Given this list of marker genes OGG1, here is a description of the gene set: studied in species Homo sapiens The majority of OGG1 mutants have been tested for their ability to excise 8-oxoguanine (8oxoG) from damaged DNA, while a small number of mutants have been tested for the ability to remove FapyG from DNA.<br>The following OGG1 mutants show at least a partial loss of their ability to remove 8oxoG:<br>OGG1 R46Q (Audebert, Chevillard et al. 2000; Audebert, Radicella et al. 2000);<br>OGG1 R154H (Audebert, Radicella et al. 2000, Bruner et al. 2000);<br>OGG1 R131Q;<br>OGG1 R229Q;<br>OGG1 P266fs139*.<br>OGG1 R46L and OGG1 R131G have not been functionally studied but have been reported in cancer and predicted to be pathogenic. They are annotated as candidate disease variants based on their similarity with OGG1 R46Q and OGG1 R131Q, respectively.<br>OGG1 S326C, a frequent variant in European and Asian populations, is susceptible to oxidation, which diminishes catalytic activity under conditions of oxidative stress.<br>The following OGG1 mutants show at least a partial loss of their ability to remove FapyG:<br>OGG1 R46Q (Audebert, Radicella et al. 2000);<br>OGG1 R154H (Audebert, Radicella et al. 2000).<br>OGG1 R46L has not been functionally studied but has been reported in cancer and predicted to be pathogenic. It is annotated as a candidate disease variant for FapyG excision, based on its similarity with OGG1 R46Q. part of: Defective Base Excision Repair Associated with OGG1 Reactome Pathway: Defective OGG1 Substrate Processing